Given this list of marker genes EGLN1, PALM2AKAP2, ALDH7A1, GNG11, SERPINF1, ENPP2, GUCY1A2 (NCBI Gene Id 2977), EMP1, PRKG1, CFH, ARHGAP29, CAVIN3, CD93, LEPR, GUCY1A1, CALCRL, SEPTIN4, OSR2, CSRP1, HTRA1, CAV1, FRZB, AP1S2 (adaptor related protein complex 1 subunit sigma 2), NDRG2, MGP, ACTB, HES4, SOX4, PDGFB, OAZ2 (NCBI Gene Id 4947), MYH9, C7, EMP2, ABCA8, SELENOP, TNS1 (tensin 1), LMNA (lamin A/C), MGST2, ARHGEF17, CHCHD10, CD151, SULF2, CCL14, IGFBP2, MDK, SLCO2B1, NR2F2, EPHX1, CD74, NDUFA4L2, RARRES2, CD9, AFAP1L1, KRT19, SERPINE2, CLEC14A, SASH1, PLAC9, PRELP, IFITM2, NOTCH4, CLSTN2, EMILIN1, BEX3, TCEAL1, LRRC17, ACSM3, RAMP2, SOD3, CTHRC1, MARCKSL1, NUAK1, EMCN, IFI27 (NCBI Gene Id 3429), COL6A2, ARHGAP18, ADCY4, CTSK, GREB1, PCAT19, C11orf96, KCTD12, CDH11, GPX3, TJP1, CLDN11, DBNDD2, ADGRL4 (NCBI Gene Id 64123), AQP1, TM4SF18, TCEAL9, ARL4A, CCDC80, GIMAP4, PEG10, ACTA2, CYB5A, HLA-DRB1, MMP2, RNASE4, TMEM98, HTRA3, ICAM2 (intercellular adhesion molecule 2, NCBI Gene Id 3384), DUSP6, SCD5, ECSCR, DYSF, OBSL1, TMEM88, CD59, LIMS1, PALMD, MEG3, RASL12, PALLD, PPP1R14A, PECAM1, TIE1, KLHDC8A, C1S, EHD4, GIMAP8, SHANK3, BCAM, PPP1R12A, MAP1B, APOD, SMAD1, LMO2 (LIM domain only 2), GJA4, NDN (necdin, MAGE family member), CDKN1C, TM4SF1, EGFL7, WNT6, ACTN4, CALM2, CCN5, HLA-DPB1, SLC40A1, CTSF, SERPING1, RHOB, CLDN5, FOXL2, MIR99AHG, BGN, EPAS1, SRGN, RGS5, AEBP1, FILIP1L, DDR2, H2AJ, IGFBP5, NUPR1, MT1E, APOE, TNFSF10, RBP1, CAV2, RBP7, MFGE8, RHOBTB3, PLK2, SGCE, FLI1, MYL6, CDH5, NFIB, TCEAL4, FLT1 (fms related receptor tyrosine kinase 1), FBN1, CCN2, LGALS3BP, JAG1, HLA-B, COL6A1, ST13, PDGFRB, MT2A, SOX18, IGFBP4, OGN, SNHG32, IFITM3, TPM1, SDC2, ELK3, IMPDH2, ISLR, GSTM3 (NCBI Gene Id 2947), MUSTN1, PEG3, IGFBP7, ARX, FXYD1, STAR, ETS2, TCF21, C1orf115, TPM2, RNASE1, MFAP4, CALD1, TSHZ2, LGALS1, PLPP3, SPRR2F, TGFBR2, GUCY1B1, CYYR1, OLFML3, HLA-DRA, CXCL12, NOTCH3, UTRN, KANK2, SVIL, PTPRB, RRAS, PKIG, FHL2, KDR, CAVIN1, PLTP, NR2F1, PCDH17, MYL9, ITGB1, MYLK, NRGN, A2M, BNC2, MEF2C, APLNR, CMYA5, S100A11, NFIC, ITGA7 (integrin subunit alpha 7), FGF7, TAGLN, MXRA8, here is a description of the gene set: The reproductive and endocrine functions of the ovary involve spatially defined interactions among specialized cell populations. Despite the ovary's importance in fertility and endocrine health, functional attributes of ovarian cells are largely uncharacterized. Here, we profiled >genes in 257 regions from the ovaries of two premenopausal donors to examine the functional units in the ovary. We also generated single-cell RNA sequencing data for 21,198 cells from three additional donors and identified four major cell types and four immune cell subtypes. Custom selection of sampling areas revealed distinct gene activities for oocytes, theca, and granulosa cells. These data contributed panels of oocyte-, theca-, and granulosa-specific genes, thus expanding the knowledge of molecular programs driving follicle development. Serial samples around oocytes and across the cortex and medulla uncovered previously unappreciated variation of hormone and extracellular matrix remodeling activities. This combined spatial and single-cell atlas serves as a resource for future studies of rare cells and pathological states in the ovary. Human Gene Set: JONES_OVARY_MACROPHAGE Marker genes selected by filtering the centroid data for genes with a value > 0 for the given cell type studied in species Homo sapiens from publication Jones ASK, Hannum DF, Machlin JH, Tan A, Ma Q, Ulrich ND, Shen YC, Ciarelli M, Padmanabhan V, Marsh EE, Hammoud S, Li JZ, Shikanov A (PMID 38578993)